Given this list of marker genes H2-M5, Cd1d1, Rab27a, Cyrib, Slc22a13, Gzmb (granzyme B), H2-M1, H2-M10.5, H2-M10.4, H2-Ea, Stx7, Gzmm (granzyme M (lymphocyte met-ase 1)), H60b, H2-T3, Mill1, Ulbp1, Ctsh, H2-M3, H2-Q7, H2-M11, 2410137M14Rik, Serpinb9b, Azgp1, Fcgr4, Fadd, H2-Q2, Emp2, Cd1d2, B2m, Raet1e, Gfus, Muc4, Ripk3, Hspa8, H2-Q1, Stx11, Il7r, Serpinb9, Ppp3cb, H60c, Nckap1l, H2-T15, Il23a, H2-M9, Raet1d, Il12a, H2-T13, Ptprc, H2-M10.3, Xcl1, Mr1, H2-M2, H2-T23, H2-Q10, H2-M10.6, Klrd1, Hprt1, Prf1, Ager, Pvr, H2-D1 (NCBI Gene Id 547343), H2-T22, H2-M10.2, Il12b, H2-M10.1, H2-T24, H2-Q4, Ceacam1, Ebag9, Pnp, H2-T5, Ctsc, H2-K1, H2-Q6, Tap2, P2rx7, Nectin2, here is a description of the gene set: studied in species Mus musculus Mouse Gene Set: GOBP_T_CELL_MEDIATED_CYTOTOXICITY The directed killing of a target cell by a T cell through the release of granules containing cytotoxic mediators or through the engagement of death receptors.